The following is a description of a gene set: Human Gene Set: GOBP_BRANCHING_INVOLVED_IN_BLOOD_VESSEL_MORPHOGENESIS species: Homo sapiens The process of coordinated growth and sprouting of blood vessels giving rise to the organized vascular system., and this is the list of marker genes: ACVR1, NRP1, DLL4, LEF1, COL4A1, MIR16-1, NOTCH4, MIR15B, PPP3R1, FKBPL, CTNND1, SIRT6, FGF8, VEGFA, STK4, GBX2, IHH, SHH, RBM15, MDK, GDF2, KDR, PLXND1, SFRP2, EDN1, SEMA3E, ABL1, TBX20, TGFBR2, GNA13, NRARP, SRF, PITX2, FGF2, EDNRA, CTNNB1, ENG, NFATC4, FOXC2